The following is a description of a gene set: Mouse Gene Set: GOMF_METAL_ION_SENSOR_ACTIVITY Binding to and responding, e.g. by conformational change, to changes in the cellular level of a metal ion. species: Mus musculus, and this is the list of marker genes: Syt4, Syt5, Efhb, Syt6, Syt17, Syt7, Syt15, Micu1, Syt10, Micu2, Micu3, Syt12, Efhd1, Syt2, Syt11, Efcab9, Syt3, Syt1, Syt13, Syt8, Slc39a4, Syt9